The following is a description of a gene set: The process in which an antigen-presenting cell expresses antigen (peptide or lipid) on its cell surface in association with an MHC protein complex. species: Homo sapiens Human Gene Set: GOBP_ANTIGEN_PROCESSING_AND_PRESENTATION, and this is the list of marker genes: CTSL, MR1, FCGR2B, TAP2, WDFY4, FAM3D, HLA-A, MARCHF1, WAS, HLA-F, PIKFYVE, NOD1, CTSS, UNC93B1, LILRB2, THBS1, CST7, MPEG1, CD209, B2M, RAB8B, ICAM1, TAP1, LGMN, HLA-E, CALR, CD1C, FCER1G, EXT1, HLA-C, HLA-DRB1, PDIA3, CD74, HLA-DPB1, SAR1B, HLA-DOA, CTSF, IDE, ERAP1, RAB27A, CD8A, HLA-DRB3, HLA-H, TAPBPL, CD1D, ULBP2, AZGP1, RAB33A, RAET1G, ACE, RAB32, ERAP2, PSMB8, HLA-B, CTSD, TREM2, AP3B1, HLA-DQB2, RAET1L, RAET1E, TRAF6, TAPBP, ARL8B, CTSV, CD68, RAB6A, RAB3B, HLA-DRB5, RAB10, RELB, HFE, DNM2, CCL19, RAB5B, CD1E, AP3D1, HLA-DQA2, IKBKB (NCBI Gene Id 3551), CD1A, CLEC4M, PYCARD, HLA-DRB4, IGHE, ULBP1, GBA1, RAB3C, RAB34, FCGR1A, CTSE, CCL21, HLA-G, YTHDF1, CLEC4A, HLA-DQB1, CCR7 (NCBI Gene Id 1236), TREX1 (three prime repair exonuclease 1), MARCHF8, IFI30, ATG5, ABCB9, CD1B, HLA-DRA, PSME1, ULBP3, SLC11A1, FGL2, LNPEP, HLA-DMB, KDM5D, RAB35, HLA-DPA1, NOD2, HLA-DMA, RFTN1, FCER2, RAB4A, HLA-DQA1, MFSD6, HLA-DOB, CTSH